The following is a description of a gene set: Binding to a chaperone protein, a class of proteins that bind to nascent or unfolded polypeptides and ensure correct folding or transport. Human Gene Set: GOMF_PROTEIN_FOLDING_CHAPERONE_BINDING studied in species Homo sapiens, and this is the list of marker genes: VWF, TBCA, PFDN4, PDPN, APP, DNAJA1 (DnaJ heat shock protein family (Hsp40) member A1), DNAJB7, PTGES3, CYP2E1, USP13, DNAJB14, CLU, DNAJB12, DNAJB4 (DnaJ heat shock protein family (Hsp40) member B4), SPN, CDC37L1, CYP1A1, BAK1, BIRC2, CTSC, NUP62, DNAJC10, PACRG, ATP1A2, BAG6, SLC25A17, HSPE1, FNIP1 (folliculin interacting protein 1), NOD2, DNAJC9, PGLYRP1, CREB1, PPEF2, HIKESHI, BAG1, HSPB6, CDC25A, DNAJC18, GRPEL1, HES1, DNAJA3, BIN1, CDC37, ERN1, HDAC8 (histone deacetylase 8), PTGES3L, BAG4, DNAJC1, BAG2, STUB1, HSPA5, DNAJB8, PFDN6, STAU2, ATP1A1, RNF207, DNAJB6, MVD, PLG, TIMM9 (NCBI Gene Id 26520), CP, SLC12A2, TBCE, TSACC, TFRC, ATP1A3 (NCBI Gene Id 95633), SYVN1, OGDH, BAG3, HLA-B, DNAJB5, PPP5C, TP53 (NCBI Gene Id 7157), WRAP53, DNAJA4, TIMM44, IQCG, DNAAF6, DNAJB2, FICD, SDF2L1, GNB5, ALB, PRNP, HSPD1, SACS, BAG5, GRN, CDKN1B, CALR, PRKN, PPID, DNAJB13, AHSA2P, METTL21A, SGTB, DNAJB1, SOD1, AHSA1, GPR37, FGB, GET4, SCARB2, TERT, AMFR, FNIP2, HSPA2, ST13, TBCC, DNAJB3, TSC1, BIRC5, LRP2, DNAJC8, HSCB, TBCD, UBL4A, CFTR, DNAJC2, SUGT1, RPS3 (NCBI Gene Id 6188), DNAJA2, SNCA, BAX, CDK1 (cyclin dependent kinase 1), GRPEL2, DNAJB9, HSPA8, ERP29, MAPT, TTC4, TIMM10, DNAJC3, DNLZ